Given this list of marker genes ARID5A, HPX, BATF, PRKAA1, CD28, SPN, C17orf99, NECTIN2 (nectin cell adhesion molecule 2), IL23R, SASH3, TREM2, CD81, HLA-B, MR1, HLA-H, FCER1G, CR1, CLCF1, IL1R1, TNFRSF1B, MSH2 (NCBI Gene Id 8169), TNFSF13B, CCR2, ULBP1, RC3H2, AHR, MAP3K7, HLA-E, HLA-G, ATAD5, TRPM4, EP300, HAVCR2, IL4I1, RIPK2, ADA, SLC22A13, PARP3, HMCES, FZD5, CLEC6A, TNFSF13, JAK3, TRAF6, CR1L, CD69, MLH1, TNF, NFKBIZ, SHLD1, CEACAM1, FBXO38, C4BPA, CD1B, XCL1, IFNA2, SECTM1, STAT5A, FCGR1A, TAP2, IL12B, PLA2G4A, KLRD1, PTPN6, HLA-A, PTPRC, CD1C, CD1E, OPA1, CARD9, USP5, AZGP1, CLC, PMS2, RIF1, PPP3CB, CCL19, SKAP1, SUPT6H, KMT5C, IL12A, NFKBID, CLEC4G, NLRP3, CD46 (NCBI Gene Id 4272), MALT1, TFRC, ALOX15, SHLD3, EIF2AK4, HLA-DRB1, ANXA1, TNFAIP3, IL18R1, FADD, TNFRSF14, WAS (NCBI Gene Id 7454), IL33, FOXJ1, ZC3H12A, JAK2, CLEC7A, NSD2 (NCBI Gene Id 7468), IRF1, RAET1L, CD7, STAT6, TNFSF4, IL2, AKIRIN2, CD40, CD226, IL23A, CD274, PKN1, NLRP10, IL20RB, PRKCQ, IL18, DENND1B, CYRIB, SLAMF1, PYCARD, EPHB2, P2RX7, IL6ST (interleukin 6 cytokine family signal transducer), IL7R, MAD2L2, BCL6, LILRB1, IL1B (NCBI Gene Id 3553), FCER2, DUSP10, RIPK3, MIR21, ADCY7, AGER, SAMSN1, SHLD2, PRKCZ, FCGR2B, RAET1G, IL1RL1, KMT5B, TGFB1, PDCD1, C4BPB, NCKAP1L, FUT7, MEF2C, NDFIP1, MAPK3 (NCBI Gene Id 5595), CD55, CD1D, ZBTB7B, IL27, TP53BP1, RC3H1, EXOSC3, UFL1, LILRB4, IFNB1, HLA-C, BRD4, CR2, BRD2, ZBTB1, TYK2, C3, HLA-F, ULBP3, CD1A, HSPD1, IL4, IL27RA, CD4, ZP3, KLRC1, SMAD7, STX7, TRAF2, CD80, CD160, APLF, SLC15A4, HLX, HMGB1, HFE, SUSD4, PVR, RAET1E, IL12RB1, RSAD2, ASCL2, YWHAG, LGALS1, IL10, JUNB, ARG1, TNFSF18, ULBP2 (UL16 binding protein 2), B2M, IRF7, PAXIP1, TBX21, IL4R, IL6, KLHL22, FOXP3, BTK, SOCS5, HLA-DRA, DUSP22, LOXL3 (NCBI Gene Id 84695), EXOSC6, LTA, SIRT1, GATA3, LGALS9, TRIM27, HLA-DRB3, SLC11A1, here is a description of the gene set: Human Gene Set: GOBP_REGULATION_OF_ADAPTIVE_IMMUNE_RESPONSE species: Homo sapiens Any process that modulates the frequency, rate, or extent of an adaptive immune response.